The following is a description of a gene set: electronically inferred by orthology from the curated human pathway This event has been computationally inferred from an event that has been demonstrated in another species.<p>The inference is based on the homology mapping from PANTHER. Briefly, reactions for which all involved PhysicalEntities (in input, output and catalyst) have a mapped orthologue/paralogue (for complexes at least 75% of components must have a mapping) are inferred to the other species. studied in species Mus musculus part of: Activation of kainate receptors upon glutamate binding Reactome Pathway: Ionotropic activity of kainate receptors, and this is the list of marker genes: Dlg4, Dlg3, Calm1, Grik5